The following is a description of a gene set: Genes down-regulated in CD4-positive, alpha-beta memory T cell 7d vs 0d in adults (18-45) after exposure to BCG vaccine, time point 7D, administered ID (intradermal). Comment: top 100 most significantly altered genes comparing Day 0 and Day 7 responses directly ex vivo Human Gene Set: HOFT_CD4_POSITIVE_ALPHA_BETA_MEMORY_T_CELL_BCG_VACCINE_AGE_18_45YO_ID_7DY_TOP_100_DEG_EX_VIVO_DN from publication Hoft DF, Xia M, Zhang GL, Blazevic A, Tennant J, Kaplan C, Matuschak G, Dube TJ, Hill H, Schlesinger LS, Andersen PL, Brusic V (PMID 28853442) species: Homo sapiens Protective efficacy of Bacillus Calmette-Guerin (BCG) may be affected by the methods and routes of vaccine administration. We have studied the safety and immunogenicity of oral (PO) and/or intradermal (ID) administration of BCG in healthy human subjects. No major safety concerns were detected in the 68 healthy adults vaccinated with PO and/or ID BCG. Although both PO and ID BCG could induce systemic Th1 responses capable of IFN-gamma production, ID BCG more strongly induced systemic Th1 responses. In contrast, stronger mucosal responses (TB-specific secretory IgA and bronchoalveolar lavage T cells) were induced by PO BCG vaccination. To generate preliminary data comparing the early gene signatures induced by mucosal and systemic BCG vaccination, CD4<sup>+</sup> memory T cells were isolated from subsets of BCG vaccinated subjects pre- (Day 0) and post-vaccination (Days 7 and 56), rested or stimulated with BCG infected dendritic cells, and then studied by Illumina BeadArray transcriptomal analysis. Notably, distinct gene expression profiles were identified both on Day 7 and Day 56 comparing the PO and ID BCG vaccinated groups by GSEA analysis. Future correlation analyses between specific gene expression patterns and distinct mucosal and systemic immune responses induced will be highly informative for TB vaccine development., and this is the list of marker genes: HSPE1, COPS2, HBA2, HBB, FABP5, PMAIP1, UBE2Z, OBI1, SAMSN1, DENND4C, AMY1B, MAFF, LUC7L3, PIM3, HBA1, CAPZA1